The following is a description of a gene set: studied in species Mus musculus Any process that stops, prevents or reduces the frequency, rate or extent of stem cell proliferation. Mouse Gene Set: GOBP_NEGATIVE_REGULATION_OF_STEM_CELL_PROLIFERATION, and this is the list of marker genes: Rarb, Cdkn2c, Trp53, Snai2, Ptch1 (NCBI Gene Id 77214), Fgf10, Nfib, AY074887, Cd109, Rbpj, Fgf2, Fbln1, Kdf1, Rarg, Sfn, Men1, Ovol2, Irf6, Gli3, Tsc22d1, Septin4, Fermt1, Nf1, Wnt11, Irgm1, Nfatc1, Cebpa, Ovol1